The following is a description of a gene set: species: Homo sapiens from publication Iparraguirre A, Tobias JW, Hensley SE, Masek KS, Cavanagh LL, Rendl M, Hunter CA, Ertl HC, von Andrian UH, Weninger W (PMID 18029397) Human Gene Set: GSE7831_CPG_VS_INFLUENZA_STIM_PDC_1H_DN CpG 1826 binds to Toll-like receptor (TLR)9, whereas influenza virus PR8 activates pDC via TLR7. Differential stimulation of pDCs is expected to result in unique activation mechanism(s) leading to a different phenotypically and functionally matured pDC We used microarrays to detail the global programme of gene expression underlying the maturation process of pDC activated with CpG 1826 and influenza virus PR8. We identified a distinct expression profile of upregulated immunomediators. Genes down-regulated in plasmacytoid dendritic cells (1h): CpG oligodeoxynucleotide 1826 versus influenza virus infection., and this is the list of marker genes: IFITM3, ELOVL3, GNG12, GDAP1, FOXD4L1, ENO3, ASS1, HSPB1, TMED10 (transmembrane p24 trafficking protein 10), LHPP, B3GALT2, CTSA, C19orf12, GUCD1, CORO1B, MTHFD2, IGFBP3 (insulin like growth factor binding protein 3), RALA, EPB41L4A, DSTN, ST3GAL2, CDX2, GRIK5, NAGA, PTPRF, CACNA1S, UBA7, CEACAM21, CD83, CD14, SLC35E4, KIF5C, SH3BGRL2, CYP7B1, MLST8, PPP2R2A, HOXB7, CYFIP1, HOXA7, DTX1, TNFRSF21, NEK6, CSTPP1 (centriolar satellite-associated tubulin polyglutamylase complex regulator 1), LDLR, LPAR1, BAAT, JAK2, CLIC4, KRT36, TMEM50B, PRKD1, LPCAT1, BTN1A1 (NCBI Gene Id 696), RAB20, RCAN3, ADAMDEC1, ALPG, CCDC115, PLD4, VWF, SPATA6, COX5A, ORM2, CMBL, LCP1, CCND1, HSPG2, CLCA1, GSN, CD80, RPL22, SIAH2, HMOX1, TCIRG1, ATXN10, SNX10, ADCY4, LYL1, AFF2, PAX8, ZNF398 (zinc finger protein 398), LSP1, AGPAT1, ADCYAP1, TRAF1, AP1B1, COCH, PISD, SLK, HLA-DOA, TRAFD1, ZFP90, SLURP1, POU2F3, RNASE4, PLPBP, CCR1, CIITA, BDKRB1, NKX2-3, PSMB9, HAX1, TNPO2, METTL1, GHRHR, ART5, KCNJ8, MARCO, ACSM2A, SSTR2, STX7, ABCC2, IL13RA1, TLR7, AMPD3, C1orf52, CER1, CIDEA, GNS, TTR, COQ5, RNF26, GJA5, RSPO1, CDH1, ERBB4, GJA10, MAPKBP1, INTS6 (NCBI Gene Id 26512), ZNF385A, ECE1, TINF2, ANXA3, STX3, AMFR, RRAGA, FGGY, FGF6, CFHR2, AHR, FOXQ1, VSNL1, UBFD1, JUN, BTG2, HMGCL, BIRC3, IRF5, NUBP1, CTSH, PSMA3, HLA-DQA1, NPL, PHEX, MAPRE3, CHRNB2 (cholinergic receptor nicotinic beta 2 subunit), MAP4K1, F11R, INTS11, LGALS3, LDB2, APIP, SLC4A4, GPR137B, LTC4S, SUMF1, ABCB1, PNPO, NEURL4, ENTPD7, SLC25A25, FCGRT, SOX10, PSMD7, NMBR, CFTR, CYB5R3, FN1, CTSZ, MZT2B, IFI35, TUFT1, AP2A2, NANOG, CKMT1B, HAP1, MED12L, ZP2, STAC, ART3, C1QC, SLCO5A1, SLC12A2, ENC1, PEG10, GRN (NCBI Gene Id 2896), TFAP2C (transcription factor AP-2 gamma), NAGK, HPGD, CYBB